Given this list of marker genes Bbip1, Ttc21b, Arl6, Gfy, Arl13a, Tub, Spata7, Pcare, Tulp1, Rom1, Arl13b, Ift80, Bbs4, Zdhhc3, here is a description of the gene set: A process in which a protein is transported to, or maintained in, a location within a non-motile cilium. studied in species Mus musculus Mouse Gene Set: GOBP_PROTEIN_LOCALIZATION_TO_NON_MOTILE_CILIUM